Given this list of marker genes NUP42, KPNA4, ISG15, PABPN1, NUP50, KPNA7, NUP85, SEH1L, NUP58, AAAS, GBP1, KPNA2, NUP98, NUP214, NUP88, NUP93, KPNA5, NUP43, TPR, NDC1, NUP210, NUP205, NUP107, NUP155, POM121, NUP54, NUP37, KPNA3, NUP62 (NCBI Gene Id 51551), SEC13, NUP153, POM121C (POM121 transmembrane nucleoporin C), MLKL, CPSF4, NUP188, RANBP2, NUP133, NS, KPNB1, NUP160, EIF2AK2, NUP35, RAE1, KPNA1, here is a description of the gene set: part of: Influenza Infection Reactome Pathway: NS1 Mediated Effects on Host Pathways Viral NS1 protein is a nuclear, dimeric protein that is highly expressed in infected cells and has dsRNA-binding activity. The RNA-binding domain lies within the N-terminal portion of the protein. The NS1 RNA-binding domain forms a symmetric homodimer with a six-helical fold. Mutational analysis has demonstrated that dimer formation is crucial for RNA-binding. The basic residues are believed to make contact with the phosphate backbone of the RNA which is consistent with an observed lack of sequence specificity. Neither NS1 nor its bound RNA undergo any significant structural changes upon binding. The NS1 dimer spans the minor groove of canonical A-form dsRNA. The non-RNA binding portion of NS1 has been termed the effector domain and includes binding sites for host cell poly (A)-binding protein II (PABII) and the 30kDa subunit of cleavage and polyadenylation specificity factor (CPSF). species: Homo sapiens